The following is a description of a gene set: Reactome Pathway: GPCR ligand binding There are more than 800 G-protein coupled receptor (GPCRs) in the human genome, making it the largest receptor superfamily. GPCRs are also the largest class of drug targets, involved in virtually all physiological processes. GPCRs are receptors for a diverse range of ligands from large proteins to photons and have an equal diversity of ligand-binding mechanisms. Classical GPCR signaling involves signal transduction via heterotrimeric G-proteins, though G-protein independent mechanisms have been reported. Rhodopsin-like receptors (class A/1) are by far the largest group of GPCRs and the best studied, though a large proportion of the functional and structural studies have focused on a very few members; many remain functionally uncharacterized. This large family can be subdivided into at least 19 subfamilies (Subfamily A1-19) based on phylogenetic analysis (Joost & Methner 2002). Family A includes receptors for a wide variety of ligands including hormones, light and neurotransmitters, encompassing a wide range of functions including many autocrine, paracrine and endocrine processes. The secretin-like family B/2 GPCRs includes receptors for many hormone-like peptides, such as secretin, calcitonin, parathyroid hormone/parathyroid hormone-related peptides and vasoactive intestinal peptide, which activate adenylyl cyclase and the phosphatidyl-inositol-calcium pathway. The class C/3 GPCRs include the metabotropic glutamate receptors and taste receptors. All have a large extracellular N-terminus that structurally resembles a clamshell and has an important role in ligand binding. studied in species Homo sapiens part of: Signaling by GPCR, and this is the list of marker genes: SSTR4, GHSR, MC4R, TSHR, CCL2, CXCL1 (NCBI Gene Id 2919), TAAR9 (NCBI Gene Id 134860), PTGER4, RXFP1, LPAR1, CCL27, PTH1R, CALCA, HCAR3, CALCB, HCAR1, PLPPR2, TSHB, WNT8A, GNGT2, EDN3, CCL25, PENK, CXCR1, CCL21, GNG2, CCL4, PTH, GPER1, GNG3, WNT7A, PRLH, OXER1, GABBR1, P2RY6, HTR1F, PROKR2, P2RY1, NTS, TAS2R20, ADRA2C, GRM6, GNG11, ADM2, TAS2R9, NPFFR2, OPN1SW, DRD3, CCL22, KISS1R, TAS2R45, LHB, DHH, LTB4R, ADRA1D, CRHBP, CXCL3, CCK, NMUR1, GPR55, CNR1, ADRA2A, TAS2R3, OPN1MW, PTHLH, APP, GCGR, TACR1, LTB4R2 (leukotriene B4 receptor 2), GNB5, S1PR4, IAPP, CASR, TAAR3P, FZD5, VIPR2, CXCL10, CCL3, FZD2, TAS2R8, PNOC, S1PR1, FSHR, CXCR5, CYSLTR1, LPAR2, CALCRL, PROK1, GPR35, NLN, P2RY14, WNT16, CRH, MC1R, WNT2, CHRM5, FFAR4, GPBAR1, TAS2R60, CXCL8, NMUR2, MCHR2, AVPR2, CXCL5, FFAR2, GNB1 (G protein subunit beta 1), CCL5, TACR2, GNRHR, NPY4R, PTGDR2, NMB, FZD9, GPR17, OXT, PTGER3, MT-RNR2, S1PR5, MTNR1A, MRGPRD, HTR1A, CHRM4, GHRH (growth hormone releasing hormone), PTGER1, SSTR5, TAS2R39, P2RY11, NMS, CXCR6, GPR143, HTR6, WNT9B, SSTR3, TAS2R50, GPR37, NPS, NPSR1, TAS2R42, PF4, WNT1, CXCR2, CHRM1, AVP, RRH, VIP, FSHB, GNGT1, INSL5, WNT3A, AVPR1A, GNG8, TAC3, MLN, NPY1R, HTR1B, NPFFR1, P2RY2, LPAR4, TAS2R38, APLNR, ADGRE2, GRM4, GNG12, PTGFR, ACKR2, GPHB5, HRH3, NPBWR1, FZD1, CXCL6, HTR1D, MC3R, ADGRE3, PPBP, GIP, CMKLR1, NPY, HEBP1, HTR2A, FPR2, GNB2, P2RY10, NMU, EDN1, C3, ACKR1, GPR65, ADGRE1, AGT (NCBI Gene Id 183), ADORA2A, UCN2, EDNRA, GNRH2, WNT8B, OPRD1, TAS2R13, AVPR1B, C5, HCRT, POMC, F2RL3, GRM8, ECE1, CYSLTR2, P2RY4, TAS2R14, KNG1, LPAR6, NPY5R (NCBI Gene Id 4889), PPY, RLN3, WNT4, PTH2, SSTR1, GABBR2, SCTR, PYY, CCL28, NTSR2, BRS3 (NCBI Gene Id 680), MLNR, SUCNR1, OPRM1, HTR2B, CHRM3, GNG13, TACR3, C3AR1, CCL1, GLP1R (glucagon like peptide 1 receptor), CCR6, GALR1, UTS2, WNT9A, FZD3, UTS2R, MTNR1B (NCBI Gene Id 4544), CXCL13, DRD2, GAL (NCBI Gene Id 51083), HCRTR1, CX3CR1, TAS1R1, ADORA1, XCL2, GNAS, GNG7 (NCBI Gene Id 90274), ADRB3, OXGR1, CCL16, ADORA2B, CCKAR, NPFF, RGR, GRPR, PTGER2, FFAR1, ACKR4, TAS2R30, ADCYAP1, KISS1, ADRA1B, F2RL1, BDKRB1, C5AR2, SMO, UCN, NTSR1, CCR5, GPR68, PMCH, TRH, ADRA2B, LPAR3, PTGIR, CXCR4, ADCYAP1R1, WNT6, PROK2, TBXA2R, TAS2R40, CCL3L1, P2RY13, TAS2R46, DRD4, LPAR5, APLN, PTH2R, S1PR3, TAAR1, PTCH1, HRH4, RAMP1 (receptor activity modifying protein 1), F2RL2, PTAFR, TAS1R2, RXFP4, HRH1, GPR37L1, TAAR8, S1PR2, GRM7, CCR7, GRP, CCL19, HCAR2, OXTR, CCR1, EDNRB, GALR3, CRHR1, CCR2, GPHA2, GLP2R, CCR9, CCL11, CCL17, HTR1E, UTS2B, TAAR5, TRHR, MAS1, HRH2, ADM, NMBR, OPN4, CNR2, NPY2R, ADORA3, TAS2R5, TAC1, WNT10B, TAS2R31, FZD8, GRM1, CCKBR, FPR3, ADGRE5, XK, PLPPR3, WNT3, PROKR1, ADRA1A, RLN2, GPR4, CCL13, VIPR1, GHRL, CALCR, RAMP2, GPR31, ECE2, CCR4, GIPR, RAMP3, CGA, HTR7, FZD6, PSAP, CRHR2, MC5R, MC2R, GCG, CCRL2, WNT2B, GNRHR2, FZD10, GHRHR, CCL23, CXCR3, WNT10A, PTCH2, GPR18, CCL7, PLPPR5, OPN1LW, LHCGR, KEL, TAS2R10, C5AR1, ACKR3, CXCL9, AGTR2, INSL3, FZD7, CXCL2, OPRK1, TAAR6, P2RY12, TAS2R41, GNB4, SSTR2, GNRH1, GNG5, SAA1, PDYN, OPN3, TAS2R4 (NCBI Gene Id 50832), TAS2R1, CD55, TAS1R3, WNT7B, EDN2, GPR132, RXFP3, BDKRB2, XCR1, PRLHR, CX3CL1, MCHR1, TAAR2, ANXA1, SCT, PLPPR1, DRD5, ADRB1, CCR10, GRM5, GPRC6A, GRM3, F2R, HCRTR2, F2, TAS2R16, FFAR3, WNT5A, FZD4, ADRB2, CXCL16, CORT, TAS2R7, HTR4, OPN5, PLPPR4, QRFP, OPRL1, PTGDR, AGTR1, CXCL11, FPR1, CHRM2, GNG4, RHO, GPR183, HTR5A, WNT11, GNB3, NPW, SHH, TAS2R19, SST, CCL20, UCN3, GNG10, RXFP2, GALR2, NPBWR2, TAS2R43, IHH, NPB, CXCL12, HTR2C, QRFPR, GRM2, XCL1, DRD1, CCR3, CCR8, GPR39